The following is a description of a gene set: Location of the urethral opening on the inferior aspect of the penis. Human Gene Set: HP_PENILE_HYPOSPADIAS Penile hypospadias species: Homo sapiens, and this is the list of marker genes: FGFR2, MTM1, SRCAP, MAMLD1, HNRNPH1, MKKS, MYMK, CYP11A1, MYMX, NIPBL, TBX22, PAICS, HOXA13, EPG5, SLC31A1